Given this list of marker genes LZTR1, CDKN1B, VANGL2, RPL10, PIK3CA (NCBI Gene Id 5290), MAD1L1, ENPP1, CCL2, MT-ND5, CDKN2B, AKT1, KCTD1, NF1, CDC73, ALX3, PRDM10, CDKN1A, SPRED1, SEC23B, MT-TS2, MEN1, MT-TH, TAF1, SDHC, KRAS, LEMD3, MFN2, MT-RNR1, TBXT, MT-TQ, TRAPPC14, FGFR1, COQ6, ALX1, MSTO1, KLLN, FUZ, BMPR1A, APC, VANGL1, MNX1, MT-TL1, PTEN, MT-TP, FLCN, AP2S1, CDKN2C, SMARCB1, MT-TK, ABCC6, ZSWIM6, HEPACAM, GNA11, NF2, SDHB, MT-TF, USF3, SDHD, here is a description of the gene set: Human Gene Set: HP_NEOPLASM_OF_FATTY_TISSUE A tumor (abnormal growth of tissue) of adipose tissue. Neoplasm of fatty tissue studied in species Homo sapiens